Given this list of marker genes LINC02591, FOXP2 (NCBI Gene Id 93986), TENM2, CALB1, CHN2, C1GALT1, IDS, APLP1, PCDH9, GAD2, SERTM1, SCGB2A1, CHD5, AQP3, AMOTL1, H2BC21, ID2, BCYRN1, ABCA5, EGR1, SHISAL2B, MEIS2, ARX, ENTPD2, METTL21A, DIRAS3, SDK1, KIAA0319, SCG2, SPOCK1, MAB21L3, PAM, NPHP4, GNAS, ID1, FGFR1, STMN2, PLPPR4, CHRM3, RFX1, BMERB1, FEV, INA, CEP126, ABCC9, YPEL2, SPC25, MRLN, CARTPT, L1TD1, FOS, SLC6A4, SAMD5, CDKN1A, DDC, DDR1, FGD4, BMF, ITM2C, KCNMB2, DPYSL3, SGSM1, STX11, TUBB2A, EPCIP, AK4, APOBEC2, MAF, GRIA3, ZNF608, TMOD1, SYNPO2, MDFIC, SLC40A1, PRKACB, PGR, RASD1, KCNJ3, EHF, IBA57, PCLO, H1-10, NKX2-2, MALAT1, INPP5F, PTP4A3, CACNA1A, NR0B1, ATP8A1 (NCBI Gene Id 10396), AKAP12, PTGFR, PON3, SREK1, PLEKHB1, PPY, PAX6, RHOBTB3, CARD11, KCNG1, MEIS1, TOX3, CALY, PGM5P2, VWA5B2, SERPINA1, THSD7A, GLT8D2, EGR3, TOX (NCBI Gene Id 9760), SLITRK6, PEG10, NEUROD1, NR4A2, CACNA1H, KCNJ8, CABP7, PCDH8, BTG2, PDK3, FGB, PCSK1N, ABCC8, FABP5, ID4, ZNF503, PXK, ETV1, LDLRAP1, MAP2, ZXDC, SEMA3E, CAMK2N1, LMO3, EGR2, CTTNBP2, DEPTOR, TMEM45B, ADGRL2, TONSL, MIR7-3HG, ACSL6, ABCB1, NEURL1, PCDH17, CSGALNACT1, TRMT9B, CXXC4, NR4A1, IL17RB, KCNQ1OT1, ISL1, TMEM47, REV3L, here is a description of the gene set: from publication Muraro MJ, Dharmadhikari G, Grün D, Groen N, Dielen T, Jansen E, van Gurp L, Engelse MA, Carlotti F, de Koning EJ, van Oudenaarden A (PMID 27693023) Human Gene Set: MURARO_PANCREAS_PANCREATIC_POLYPEPTIDE_CELL species: Homo sapiens